Given this list of marker genes Ctnnb1, Wnt7b, Eng, Wnt7a, Rtn4, here is a description of the gene set: studied in species Mus musculus Mouse Gene Set: GOBP_CENTRAL_NERVOUS_SYSTEM_VASCULOGENESIS The differentiation of endothelial cells from progenitor cells during blood vessel development, and the de novo formation of blood vessels and tubes in the central nervous system. The capillary endothelial cells in the brain are specialized to form the blood-brain barrier.